The following is a description of a gene set: Any process that results in a change in state or activity of a cell or an organism (in terms of movement, secretion, enzyme production, gene expression, etc.) as a result of a heparin stimulus. Human Gene Set: GOBP_RESPONSE_TO_HEPARIN studied in species Homo sapiens, and this is the list of marker genes: GPIHBP1, EXT1, EGR1 (NCBI Gene Id 1958), SOX9, SLIT2, CDH1